Given this list of marker genes EEF1AKMT4-ECE2, LGMN, APP, ADAMTS6, TIMP1, ADAM9, CELA2A, ADAM23, RHBDL2, PRSS3, BIRC7, CTSC, CMA1, CST9L, ECE2, HTRA1, PRSS37, SLCO1B3, SERPINE3, NAIP, PSMF1, CTSF, CASP4, WFDC2, CST9LP1, SPINK6, NGF, HTRA2, RHBDD3, MANSC4, PARL, USP6, ATG4B, PCSK1, COL28A1, TRABD2B, SPOCK3, ESPL1, CSTB, BIN1, KLK14, HPR, PRSS29P, PSMA6, CASP7, SPINK14, KLK2, CTSS, NLRP1, ADAMTS19, CASP8, MMP13, KLK5, PCSK4, ADAMTS14, CTRL, SERPINB5, CAST (NCBI Gene Id 831), CASP6, NLRP7, CIROP, CARD18, PROS1, WFDC8, SPPL2C, PSENEN, OVCH2, SERPINE2, TPSAB1, CAPNS2, ADAMTSL2, TMPRSS11A, SERPINA5, ADAM15, WFDC11, CASP3, KLK10, TPP1, PSMB7, SERPINF1, CLCA1, SENP1, MMP11, TMPRSS7, SLCO1B3-SLCO1B7, ADAMTS13, TLL1, KLK8, PSMB6, GBP2, HP, TMPRSS2, MMP3, ADAMTS15, CST4, USP48, KLK3, A2M, CELA3A, PSME2, TMPRSS11B, WFDC10B (NCBI Gene Id 280664), TPP2, ADAM8, PIP, USP29, ADAM11, DDI1 (NCBI Gene Id 414301), MMP1, DAG1, ADAMTS5, HGFAC, CFD, PSME3, PZP, PRRG3, USP13, SERPINE1, RHBDL3, CST2, SERPINH1, MMP14, TMPRSS4, KLK4, USP33, CSTL1, SERPINI1, NLRC4, MMP12, TFPI2, ITIH5, NLN, PMPCA, PAPLN, TMPRSS9, FURIN, ERAP1, MMP24, MASP1 (MBL associated serine protease 1), CTSE, CELA2B, PRRG4, NLRP3, PSMD14, CTSL, ADAM7, BACE1, MMP15, CST1, SMR3B, SEC11B, USP16, KLKB1, GZMA, CAPNS1, GZMH, ADAM22, PGA3, ITIH2, CSTA, RHBDF2, SPINK13, BMP1, PEBP1, MMEL1, APH1A, PDIA3, MMP25, TFPI, PTTG1, PROC, SERPINA6, CARD16, PRSS56, SMR3A, PSMB9, NAPSA, CAPN9, PRSS45P, SPINK4, CTSK, KLK11, MMP17, AIM2, PHEX, KLK1, UQCRC2, ADAM20, TYSND1, PRTN3, KLK6, PIDD1, ADAMTS18, CAPN10, SENP7, SPINT4, PGC, SERPINA3 (serpin family A member 3), JMJD7, CPNE1, KEL, SERPINB1, C2, SPINK7, ASTL, ADAMTS20 (ADAM metallopeptidase with thrombospondin type 1 motif 20), CELA1, WFDC1, PRSS54, USP14, CTSW, ASPRV1, USP37, MASP2, KLK7, PAPPA, TMPRSS15, WFIKKN1, VSIR, ST14 (NCBI Gene Id 6768), USP20, ERAP2, NDUFA13, HABP2, CFB, PRSS27, SERPINB6, CD109, KDM8, GZMB, PRSS41, WFDC5, ST20, MMP19, PRSS23, PLAT, FETUB, OMA1, THOP1, PCSK5, APEH, LCN1, HM13, PAPPA2, TPSB2, LONP2, LONP1, SLPI, CASP14, HGF, SERPINF2, F2, SERPINA2, NLRP12, CASP2, SPPL3, CSN2, SERPINA12, IMMP1L, XIAP, TPSD1, CARD17P, F3, PSEN1, AZU1, USP8, KLK12, BACE2, HMSD, USP10, SPRTN, SHH, NCSTN, GPAA1, CST7, SERPINB12, ADAMDEC1, CAPN5, ADAM29, SERPINB3, MMP27, COL4A3, SPPL2B, BAD, TIMP2, RHBDL1, SERPINA10, KLK9, C5, ADAMTS2, CTSD, TMPRSS13, CRIM1, ABCA2, UCHL5, HRG, PSEN2, ADAM28, YME1L1, TLL2, ATG4D, LTF, SERPINA7, TMPRSS3, MALT1, USP5, ADAMTS9, CTRB1, PRRG1, USP9X, MBTPS2, TIMP3, YBEY, PRSS21, SERPINB13, MST1, F7, MIPEP, C4A, TMPRSS11D, SLCO1B7, ROCK2, PCSK7, PRSS36, TINAG, SERPINC1, LXN (NCBI Gene Id 56925), WFDC9, SERPINA11, PRSS51, PCSK2, USP1, PLG, PRNP, CST5, WFDC10A, ITIH4 (NCBI Gene Id 3701), SPOCK2, CASP5, RHBDF1, CARD8, PSME1, MME, PREPL, PRSS12, PSMB5, ADAM2, CRB2, ADAMTS7, PSMB8, SERPINI2, GZMK, LMLN, COL6A3 (collagen type VI alpha 3 chain), REN, F11, ANXA2, NRIP3, TASP1, PIGU, CASP9, NRIP2, SENP5, ADAM12, CTRB2, MMP7, PRSS48, KNG1, KLK13 (kallikrein related peptidase 13), ADGB, TIMM50, C3P1, ADAM10, CAPN15, TMPRSS11F, PRSS3P2, SFRP2, SFRP1, MMP9, MMP8, ADGRG6, CASP10, SPINT1, PI3, RCE1, PRSS58, AHSG, ITIH3, HTRA4, ATP23, CTSH, PRSS8, PIGK, AMBP, ADAM18, CAPN6, LPA, RECK, MMP28, APH1B, ATG4C, CAPN13, CAPN7, UBAC2, TPSG1, MEP1B, CTSO, CPAMD8, SERPINB7, BLMH, PSMB10, TMPRSS5, ZMPSTE24, NRDC, USP34, WFDC12, PREP, MEP1A, ADAMTS4, USP12, ECE1, MMP20, ADAMTS17, APLP2, SERPINB8, SPPL2A, HSPD1, SERPIND1, ADAMTS10, USP49, ADAM33, C1S, CAPN11 (calpain 11), WFDC6, ITIH6, BIRC5, SEC11C, PRSS42P, CLCA4, SPP2, GAPDH, PROZ, TMEM59, CST3, USP2, USP15, ADAM19, CAPN2, CLCA2, MMP21, F10, USP11, C1RL, SPINT2, CAPN14, RHBDD1, PYCARD (PYD and CARD domain containing), MMP16, SERPINA1, SERPINA4, SORL1, CPS1, SERPINB2, C4B, CORIN, CST8, CELA3B, OPRPN, PLAU, ADRM1 (ADRM1 26S proteasome ubiquitin receptor), SERPINB4, MST1L (NCBI Gene Id 11223), SPINK1, SENP2, GBP5, ITIH1, PITRM1, ACE2, BST2, EPPIN, PRSS53, AGT, PRSS22, TMPRSS6, HPN, CTSB, WFDC13, MMP23B, DDI2 (NCBI Gene Id 84301), USP7, CFLAR, APAF1, CTSV, SPINK5, TMPRSS11E, HTRA3, C3, SPINT3, CAPN3, SERPINB9, BIRC6, ADAM17 (NCBI Gene Id 6868), SNCA, ADAMTS8, RHBDD2, KLK15, F12, COL7A1, PIK3IP1, PRSS38, ECEL1, PSMB11, TIMP4, PRSS33, SENP6, MBTPS1, CASP1, TRABD2A, PRSS1 (serine protease 1), CTSZ, ELANE, ADAMTS1, FAP, SERPINA9, PRRG2, SPINK2, CST11, CST6, IDE, SEC11A, SPG7, MMP10, PCSK1N, PCSK6, RENBP, OVCH1, ADAM30, SPINK9, ANOS1, DPP4, PGA4, CASP12, PRSS50, GZMM, F9, ATG4A, SERPING1, MMP2, WFDC3, CFI, CTRC, CLPP, WFIKKN2, USP30, SERPINB11 (NCBI Gene Id 89778), CTSG, PRSS55, A2ML1 (NCBI Gene Id 619538), CAPN8, TMPRSS12, CST9, UCHL1, PRSS47P, PRSS57, SPOCK1, PRSS46P, CAPN1, C1R, ADAMTS12, THBS1, PRSS2, MMP26, USP27X, ADAM32, ACR, IMMP2L, PMPCB, SERPINB10, ADAMTS16, SPINK8, ADAM21, PGA5, AFG3L2, ADAMTS3, RARRES1, CAPN12, PCSK9, ACE, here is a description of the gene set: Human Gene Set: GOMF_ENDOPEPTIDASE_ACTIVITY Catalysis of the hydrolysis of internal, alpha-peptide bonds in a polypeptide chain. species: Homo sapiens